The following is a description of a gene set: Reactome Pathway: Mitochondrial ribosome-associated quality control Translation can stall due to lack of tRNAs or due to defects in mRNAs and tRNAs. A stalled mitochondrial 55S ribosome is bound to an mRNA, a tRNA at the exit site (E site), a peptidyl-tRNA at the P site, and a nascent polypeptide covalently attached to a nascent polypeptide covalently attached to the P-site tRNA (that is, a peptidyl-tRNA).<br>In the case of a defective tRNA, dissociation of the complex is initiated by the separation of the 39S and 28S subunits of the stalled 55S ribosome. The MALSU1:MIEF1:NDUFAB1 complex, which normally binds the 39S subunit prior to subunit association during translation initiation, also plays a role in either initiating or maintaining separation of the subunits of the stalled ribosome, as the complex is observed to be associated with the dissociated 39S subunit of a stalled ribosome. The E-site tRNA, the peptidyl-tRNA, and the nascent polypeptide remain bound to the 39S subunit.<br>Subsequent to dissociation of the 39S and 28S subunits, the MTRFR:MTRES1 complex binds the 39S:tRNA:peptidyl-tRNA:polypeptide complex, probably resulting in the ejection of the E-site tRNA. MTRFR binds the empty A site of the ribosome and MTRES1 binds the anticodon stem-loop of the peptidyl-tRNA. The MTRFR subunit of the MTRFR:MTRES1 complex is thought to hydrolyze the nascent polypeptide from the peptidyl-tRNA, regenerating the tRNA. MTRFR then ejects the nascent polypeptide and MTRES1 ejects the P-site tRNA.<br>In the case of a mRNA lacking a stop codon (non-stop mRNA), the ribosome translates to the 3' end of the mRNA. Without a stop codon, neither of the normal mitochondrial translation termination factors, MTRF1L (MTRF1A) or MTRF1, are recruited to the A site of the ribosome to release the nascent polypeptide from the peptidyl-tRNA. Instead, the empty A site and empty mRNA channel are recognized by ICT1 (MRPL58) which extends its elongated C-terminal region into the mRNA channel. ICT1 then hydrolyzes the peptidyl-tRNA bond to release the nascent polypeptide and regenerate the tRNA. The ribosome is then recycled to yield separate 39S and 28S subunits by an uncharacterized mechanism. part of: Mitochondrial translation species: Homo sapiens, and this is the list of marker genes: MRPS10, MT-RNR1, MRPL23, MRPS7, MT-TT, MRPL45, MT-TH, OXA1L, MRPL46, MRPS27 (NCBI Gene Id 64948), MRPL21, MRPL57, MRPL54, MRPL3, MRPL22, MRPL53, MRPL32, MRPS15, MT-TD, MRPL10, DAP3 (NCBI Gene Id 7818), MIEF1, MRPS33, ERAL1, MRPS21, MRPL44, MT-TR, MRPS6, MRPL28, MRPL19, MRPL17, MRPS18B, MRPL30, MRPL49, MRPS17, MT-RNR2, MRPS18A, MRPS12, MRPL39, MRPL1, MRPL34, MT-TY, MRPL36, MRPL55, MRPS2, MRPL37, MRPL33, MRPS11, MRPL12, KGD4, MRPL52 (NCBI Gene Id 122704), MT-TS2, MRPL14, MT-TC (mitochondrially encoded tRNA-Cys (UGU/C)), MT-TP, MRPL40, MRPS14, GADD45GIP1, MTRES1, MT-TK, MRPS31, MRPL27, MRPL58, MRPS16, MRPL51 (NCBI Gene Id 51258), MRPS35, MRPS9, MRPS25, MT-TN, MT-TL2, MRPL42, MT-TE (NCBI Gene Id 4556), MT-TF, CHCHD1, MALSU1, MRPS30, MTRFR, MRPL18, MRPL24, MRPL47, MRPL15 (NCBI Gene Id 65001), MRPL20, AURKAIP1, MRPL11, MRPS23, MT-TQ, MRPL35, MT-TS1, MRPL50, MRPL41, MRPS24, MRPL43 (NCBI Gene Id 84545), MRPL16, NDUFAB1, MRPS18C, MT-TA, MT-TI, MT-TM, MRPL13, MT-TG, MRPL48, MRPL38, MRPS5, MRPS26, MRPL4, PTCD3, MRPL9, MRPS22, MRPL2, MRPS34, MT-TL1, MRPS28, MT-TV, MT-TW